Given this list of marker genes MTHFR, IL10 (NCBI Gene Id 3586), F2, HLA-B, HABP2, AEBP1, TLR4, UBAC2, PRORP, KLRC4, ERAP1, IL12A-AS1, FAS, CCR1, TGFB2, AKT1, SERPINC1, PROS1, PROC, IFNGR1, C4A, STAT4, F13A1, MEFV, IL12A, IL23R, here is a description of the gene set: Thrombophlebitis Inflammation of a vein associated with venous thrombosis (blood clot formation within the vein). Human Gene Set: HP_THROMBOPHLEBITIS studied in species Homo sapiens